The following is a description of a gene set: species: Mus musculus Mouse Gene Set: WP_IL2_SIGNALING_PATHWAY IL-2 signaling pathway, and this is the list of marker genes: Vav1, Hsp90aa1, Pik3ca, Jak3, Cd53, Mtor, Map2k1, Eif4e, Ptpn11, Cish, Foxo3, Crk, Jak1 (NCBI Gene Id 319959), Il2rb, Socs1, Il2rg, Pik3cd, Cbl, Plcb1, Stam, Fyn, Socs3, Ets1, Gab2, Irs1, Mapk14, Irs2, Jak2, Rela, Ybx1, Pik3cb, Pik3r1, Kras, Creb1, Mapk1, Pik3r2, Ifna1, Lyn, Stam2, Stat5a, Shb, Pik3cg, Akt1, Stat5b, Ets2, Nr3c1, Rack1, Sos1, Mknk1, Map2k2, Itm2b, Prkcz, Ptk2b, Icam1, Mapk3, Shc1, Mapk8, Bcl2 (NCBI Gene Id 98734), Stat3, Eif3b, Mapkapk2, Crkl, Nmi, Il2ra, Nfkb1, Grb2, Il2, Lck, Raf1 (NCBI Gene Id 76876), Mapk9, Stat1, Rps6kb1, Ptpn6, Syk, Tert, Chuk (conserved helix-loop-helix ubiquitous kinase)